The following is a description of a gene set: studied in species Homo sapiens Human Gene Set: GSE13485_DAY1_VS_DAY7_YF17D_VACCINE_PBMC_DN from publication Querec TD, Akondy RS, Lee EK, Cao W, Nakaya HI, Teuwen D, Pirani A, Gernert K, Deng J, Marzolf B, Kennedy K, Wu H, Bennouna S, Oluoch H, Miller J, Vencio RZ, Mulligan M, Aderem A, Ahmed R, Pulendran B (PMID 19029902) Genes down-regulated in comparison of unstimulated peripheral blood mononuclear cells (PBMC) 1 day after stimulation with YF17D vaccine versus PBMC 7 days after the stimulation. The immune responses generated by YF-17D by profiling genes in 25 vaccine recipients were accessed at days 1, 3, 7, and 21 post-vaccination compared to pre-vaccination in PBMCs. The immune responses generated by YF-17D by profiling genes in 25 vaccine recipients were accessed at days 1, 3, 7, and 21 post-vaccination compared to pre-vaccination in PBMCs., and this is the list of marker genes: GBP4, IFIH1, COPS5, OASL, PIK3AP1, LGALS3BP, FMNL2, HMOX1, TYMS, PLSCR1, STAT1, SNAPC5, CHMP5, IFIT5, CRNKL1, DUSP6, MPLKIP, PSMA4, NAT1, MRPL27, PARP14, IFIT1, TLR7, CXCL10, BLVRA, RRM2, SNX6, IFI44L, LINC00487, ZNF41, TRIM22, RGL1, PLAC8, PHF11, PSMB9, FANCL, SLC31A2 (NCBI Gene Id 1318), IFI44, XAF1, YIPF5, PARPBP, APOL6, BMP2K, C3AR1, CD58, NEXN, APOBEC3A, TET2, WARS1, PARP9, IRF7, IFI6, CCR1, BMPR2, OAS2, EPSTI1, SLFN12, CALHM6, CAPZA1, CCDC90B, C1GALT1C1, ANAPC10, LYSMD2, PARP12, DTX3L, PSME2, CASP1, SIGLEC1, GBP1, HEG1, SAMD9, DDX60L, TMEM255A, MRPL42, GMPR, TMEM50B (transmembrane protein 50B), HAUS1, SRBD1, TLR4, IFITM1, CLIC2, LINC00324, RBBP8, TDRD7, CARD6, PBK, NDUFB3, CSE1L, TNFSF10, LMBRD2, USP18, SFT2D1, GMEB1, MSH2, MX2, RIN2, HAVCR2, CCR5, GCH1, CMPK2, AIM2, MYOF, CTSL, IFIT3, MRPS18C, SAMD9L, GBP3, TM9SF1, SMC2 (structural maintenance of chromosomes 2), OAS1, TMEM126B, KLHL12, HERC6, DHX58, ATP6V1D, SECTM1, ZSCAN16, MAIP1, NCOA7, ZNRF2 (NCBI Gene Id 223082), RIGI, ATP6V0E1, POP4, TOR1B, NMI, ZNF684, DDX60, SERPING1, COMMD10, ZWINT, SKA2, TMEM268, PI4K2B, KLHDC7B, CALML4, FNIP2, EIF2AK2, SHFL, MARCKS, GINS1 (NCBI Gene Id 9837, GINS complex subunit 1), SP110, IFITM3, PNPT1, ADAR, SUCLA2, RTP4, ATP11C, IFNAR1, TRIM5, LRR1, ISG15, FBXO6, ZBP1, ABHD6, SCAMP1-AS1, LAMP3, LIPT2-AS1, DPH3, PSMA5, MVB12A, SAMD4A, VRK2, AURKA (NCBI Gene Id 8465), LAP3, SP100, LAMTOR3, AZI2, IFI27, RTCB, KMO, OSTM1, TAP1, TUBD1, CASP5, HERC5, C4orf33, CD38, PPP2R3C, OAS3, THAP9, KIF23, MX1, ZNF410 (NCBI Gene Id 57862), MRPS28, TBC1D23, TRIM69, MS4A4A, IFIT2, IL1RN, SPATS2L, EFR3A, SCARB2, TLR1, RSAD2, UBE2L6, MRPL13, CASP7, RFC5